The following is a description of a gene set: Human Gene Set: REACTOME_SUMOYLATION_OF_RNA_BINDING_PROTEINS studied in species Homo sapiens SUMOylation of RNA binding proteins, and this is the list of marker genes: RAE1, RANBP2, NUP133, NUP210, SUMO1, POM121, NUP85, NUP107, POM121C (POM121 transmembrane nucleoporin C), HNRNPK, NUP160, NUP153, RNF2, UBE2I, NUP50, CBX2, CBX8, NUP42, NOP58, NUP37, NUP214, NUP35, BMI1, PHC2, PCGF2, NUP43, NUP98, NUP188, NUP205, NUP93 (nucleoporin 93), NUP62, HNRNPC, SEH1L (SEH1 like nucleoporin), NUP58, NUP88, SCMH1, TPR, AAAS, NDC1, PHC1, CBX4, PHC3, NUP54, RING1, NUP155, SUMO2, SEC13